Given this list of marker genes LPAR1, ZNF451, MAT2A, GANAB, EMG1, DDX1, MATR3, KRCC1, RAB10, ST8SIA4, TMEM123, ATG101, ZNF322, HSDL2, CNOT6, ZNF146, PAPOLA, CHSY1, LRPPRC, RB1CC1, ALCAM, HMGCS1, RPRD1A, USP38, USF1, ZBTB33, XRN1, RABGAP1, NIN, CMTR2, DNAJC15, CHCHD4, TOP2B, SLC38A2, GLUD1, WDFY1, UPF2, PPP4R3A, DOCK11, BAZ2B, ICAM3, CHD9, PPP6R3, RFX7, MOSPD2, ZNF263, MRPL27, GFM1, EFR3A, RMI1, FAR1 (fatty acyl-CoA reductase 1), PUM2 (pumilio RNA binding family member 2), SRPRB, DNAJA2, BCLAF1, C6orf62, ARHGAP24, ABHD10, DNAJC10, HDAC2, VCF1, MSL3, BIRC2, COX15, CPED1, TDG, EIF2S1, ALG6, PDS5A, BLCAP, PJA2, CEPT1, SCYL2, NOC3L, PPM1B, PIGN, AGL, CERS6, MKKS, MAP3K7, YTHDF3, ACBD3, BTLA, SLMAP (NCBI Gene Id 7871), ZNF480 (NCBI Gene Id 147657), BCL11A, FAM13B, GLE1, VPS13C, SLC43A3, EIF4G2, MAP3K1, MTMR10, SLC18B1, CLN5, VPS41, FOXN2, TXNDC9, PAK2, RCN1, USP7, COBLL1, HAPSTR1, PFDN5, RNF20, ARMC1 (armadillo repeat containing 1), ZNF26, ZNF518A, C5orf15, TUT7, RAB8B, PPP2R5A, DCP2, CUL4B, DMAC1, FAM117B, RAB33B, NIPBL, CPSF3, EXOC6, PSMC1, TRAK2, NECAP2, STAT5A, SERBP1, AKAP8L, BST2, here is a description of the gene set: studied in species Homo sapiens from publication Thakar J, Mohanty S, West AP, Joshi SR, Ueda I, Wilson J, Meng H, Blevins TP, Tsang S, Trentalange M, Siconolfi B, Park K, Gill TM, Belshe RB, Kaech SM, Shadel GS, Kleinstein SH, Shaw AC (PMID 25596819) To elucidate gene expression pathways underlying age-associated impairment in influenza vaccine response, we screened young (age 21-30) and older (age >= 65) adults receiving influenza vaccine in two consecutive seasons and identified those with strong or absent response to vaccine, including a subset of older adults meeting criteria for frailty. PBMCs obtained prior to vaccination (Day 0) and at day 2 or 4, day 7 and day 28 post-vaccine were subjected to gene expression microarray analysis. We defined a response signature and also detected induction of a type I interferon response at day 2 and a plasma cell signature at day 7 post-vaccine in young responders. The response signature was dysregulated in older adults, with the plasma cell signature induced at day 2, and was never induced in frail subjects (who were all non-responders). We also identified a mitochondrial signature in young vaccine responders containing genes mediating mitochondrial biogenesis and oxidative phosphorylation that was consistent in two different vaccine seasons and verified by analyses of mitochondrial content and protein expression. These results represent the first genome-wide transcriptional profiling analysis of age-associated dynamics following influenza vaccination, and implicate changes in mitochondrial biogenesis and function as a critical factor in human vaccine responsiveness. Human Gene Set: THAKAR_PBMC_INACTIVATED_INFLUENZA_AGE_21_30YO_NONRESPONDER_7DY_UP Genes up-regulated in peripheral blood mononuclear cell 7d vs 0d in young adults (21-30) (nonresponder) after exposure to Inactivated influenza vaccine, time point 7D